Given this list of marker genes Mapk8, Prkcd, Pmp22, Dll1, Cdk5, Ccl12, Gas6, Trem2, Igf1 (insulin-like growth factor 1), Prkca, Rad21, Akap12, Cers6, Traf2, Prkci, Prkch, here is a description of the gene set: species: Mus musculus Any process that modulates the frequency, rate, or extent of glial cell apoptotic process. Mouse Gene Set: GOBP_REGULATION_OF_GLIAL_CELL_APOPTOTIC_PROCESS